Given this list of marker genes PPARGC1B, MAP3K6, DPF1, OPRL1, ASB7, CACNB1, MYBPH, ZDHHC14, OGDH, ELAVL4, TTN, MBD3, ACR, KIF1C, CCN3, PCBP4, ISL1, TOMM40L, FGF17, TUBGCP6, PRSS36, GABBR2, NRIP3, PTPRF, GCH1, FBXO3, CYBC1, FNDC5, GSPT1, CREB3 (NCBI Gene Id 10488), MYO18A (NCBI Gene Id 9799), ZBED5, SEMA6C, TP53BP1, IRS1, AP4S1, CHRD, IGDCC4, RLIM, FAM131C, AHNAK, DDX17, KLF13, INTS9, AGBL5, HS3ST2, EPO, ATP1B2, TIGD4, TP53, ARHGEF2, DDAH2, NR2F1, CBFB, DCTN1, AGER, PIP5K1B, AXL, AAK1, RRAD (RRAD, Ras related glycolysis inhibitor and calcium channel regulator), NECTIN1, BRD2, LRP5, MYL2, SLC12A5, MAP1LC3A, CACNA1A, REEP4, WNT5A, USF2, BMF, PFDN1, MAP3K11, TAOK1, GRIK1, SLC39A6, TAFA1 (NCBI Gene Id 494552), PA2G4, HAUS3, MAST2, JOSD2, FOXA2, WASF2, HOXC6, HS3ST4, HBEGF, NTN1 (netrin 1), DTX1, CPNE5, RPL10A, H2AC21, NAT8L, PTK2B, RAPGEFL1, GNAO1, TRAPPC3, IL2, ZFYVE1, MLLT10, SREBF2, UNG, ARRDC3, TMEM139, ITPKB, ZNF516-DT, FOXI1, SMARCB1, NUFIP2, LRFN4, GPR20, BMP7, DCX, BMP4, PPP2R3C, SEMA6A, ZBTB9, SP2, TLX2, PNKD (NCBI Gene Id 87830), ELOVL6, SLC16A2, RIPOR1, CERCAM, HOXB4, PMP22, TRIM46, MSC, S100A10, KLK7, CLC, LINC00656 (long intergenic non-protein coding RNA 656), CAV3 (caveolin 3), PLEKHA4, SFSWAP, PLEKHN1, ADAMTS12, CYLD, IL2RG, PRR7, RARRES2, LNPEP, CALML5, UBE2D3, RPRD2, RBL1, AQP4-AS1, ITGA5, PAX6, HSD11B1 (NCBI Gene Id 3290), ZEB1, ZSWIM3, LDB1, HOXB8, ZHX2, OSR1, KLF5, ZNF436-AS1, SLITRK2, STAG3, COL11A2, DNAJC7 (DnaJ heat shock protein family (Hsp40) member C7), RHEBL1, NR5A1, CIAO1, CDKN1B, TNIP1, C11orf87, CD38, TRIM55, GPC2, KMT2E, JUP, CDK6, CTNND2, TCEA2, MAP4, CAST, ZBTB7A, DDIT4, YBX3, PDK3, ABI3BP, GSE1, PTCHD1, VIM, PRDM1, RASSF2, FCGBP, SIX2, SBF2, ZFAND5, PPM1B, TLNRD1 (talin rod domain containing 1), H2AX, ATOSB, QPCT, TXLNG, DNAJC14, HDAC8, DBNDD2, POU2F1, KCNK10, SP7, SPARC, ASPHD1, ABHD1, EVX1, DTNA, TOM1L1, PPP2R2B, ESAM, IGSF3, DSG3, VPS16, SERPINB7, LUC7L2, HAS1, ADA, GNB2, IGFLR1, CRLF1, LAT, SHC1, HOXB2, GNAI2, NREP, CDKN1A, NMT1, ARHGEF15, TSPAN4, ERLIN1, MEF2D, TMSB4XP8, RAB1A, PTPN6, RFX1, PROCR, BCAR3, ZNF827, HNF1A, PTCH1, CLASP1, PRDX2, ITGA6, UBE2B (NCBI Gene Id 7320), SOX15, IGF2, AP1G1, OGA, NEUROD2, AQP4 (NCBI Gene Id 50660), ADORA2A, FRMD4A, NECTIN4, SEMA3G, LENEP, SPTAN1, PTMS, GPR119, PRRX1, GPM6B, ATP1A3, SH3GLB2, POLR2L, ATN1, KCNA1, RAC1, SPTBN4, STARD13, RAD23A (NCBI Gene Id 5886), DLX1, MSLN, PHF12, NTN4, PITX2, SPTY2D1, LYPD1, LINC00472, VCAN, NIN, PTPN12, NCAM2, TPM3, TLN1, MYL3, DOCK11, ATP6V1A (NCBI Gene Id 523), CD27, PKP3, AKTIP, WNT3, TSPAN17, PBXIP1, TPPP3, IGSF1, CDC42SE1, SRSF1, SIAE, CADM2, MAN2B1, TRIM39, SLCO2B1, TEAD3, SYNPO2L, EMILIN1, EFNB3, SERTAD4, PHLDB3 (pleckstrin homology like domain family B member 3), ADGRD1, RTKN, RBM3, WNK4, STAG1, SIK2, RASAL2, IMPDH2, JADE3, CLVS1, ARHGAP32, SLC38A5, ABI3, HDGF, RADIL, EIF4E, DLL4 (NCBI Gene Id 54567), NAA50, COL5A3, ENTPD1, FGFR1 (fibroblast growth factor receptor 1), TNKS1BP1, SLC4A1, CA11, LINC00303, MRTFA, FAM13B, ARL4C, CPNE9, JADE2, PPP2R5B, GABARAP, CITED1, SEPTIN7, CSK, NCALD, TAOK2, KRTCAP2, SHH, GUCA2B, GRIN2B, AZIN1, CACNA1E, MKNK2, MAP4K3, CD63, FBXO5, FAM120AOS, FBRS, DUSP8, KLHL40, EIF1AX, DMPK, DENND5A, SAMD1, MRPL49, SPHK1, ITGA2, RTN4, PAFAH1B1, HOXB6 (NCBI Gene Id 3216), FZD7, EEF1A1, WBP1, HOXC11, HNF1B, HCFC1R1, CCDC81 (NCBI Gene Id 60494), HNRNPF, HOXB13, TFAP2B, MID2, TSPAN1, CIP2A, KREMEN1, THBS3, DUSP5, TUBA4A, PKIA, LDHD, EN1, TMEM270, RNF11, ZNF296, CD109, LUC7L, PCGF5, EMSY, CCDC71, TAL1, CLIP3, KRTAP11-1, INHBE, NLGN3, BRWD3, PPM1D, RAD23B, PBX1, MPC2, ADD3, PYY2, NR1D1, PTPRN, KIF3C, FOXN3, PSD, NYAP1, RCOR2, FHL1, LGI2, PLCD4, CADM1, UBE2W, EHMT2, PFKFB1 (6-phosphofructo-2-kinase/fructose-2,6-biphosphatase 1), PRM2 (protamine 2), RPS6KA4, KCNMB1, SIX4, TAX1BP3, SHROOM1, GSX1, RASL11B, CSNK2A1, GIGYF1, DDA1, KLHL28, PTGR3, SKIL, DLG3, BAZ2A, FOLR1, PRKCE, TNPO3, LRRN2, EIF1AY, TSPAN13, UBE2F, NLGN2, BTK, DEPDC4, OAZ2, SLC9A6, SOX14, SPRY4, LRP1, RASIP1, KRT13, THPO, MN1, RTN4RL2, KPNB1, ARHGAP45, USP2, EDA, IRF9, PICALM, FXYD7, CYP26B1, SKIDA1, DEDD, WRAP53, GTF3C4, NR4A1, GRIA3, KAT5, PCSK1N, ARHGAP30, LRRTM4, HOXA10, ATP8B2, DPYSL5, EHF, TOGARAM1, SHKBP1, HSPA12B, ATG13, SLC25A37, TUBA4B, ADNP2, GADD45B, SRSF2, ANGPTL7, NHLH1, ETV5, MMP28, MPP2, C1QTNF7, AASDHPPT, PHKG2, SERPINE1, TRHDE, MOV10, NEDD4, ELK3, BARHL1, IGF2BP1, PPL, SEMA4C, DHCR24, HNRNPA2B1, NDRG2, C14orf119, TRIM41, C1QL1, ANXA4, ZBTB11, PHACTR3, SEMA7A, MAB21L3, BRD4, PPFIA2, KNTC1, MSN, WDR13, LINC02873, FGF11, USP12 (ubiquitin specific peptidase 12), CLCN6, DDX31, SPEN, SBSN, GNB4, SERPINB5, EBP, CCNA2, PRKAR2B, NHLRC2, TOR1AIP2, RAB25, HNRNPC, JMJD1C, MAG, CD55, SERPINI1, XPO7, FZD4, SMAD6, KLF3-AS1 (NCBI Gene Id 79667, KLF3 antisense RNA 1), ROGDI, PHYHIP, EPC1, HNRNPL, PRELP, IQGAP2 (IQ motif containing GTPase activating protein 2), KLF12, GPR173, SFRP1, DMTN, KCNH2, TAFAZZIN, TREML2, RMI1, CKMT1B, UBE4B, RUNDC3A, EFNB2, NOTCH2NLA, KRTAP6-1, HAPLN1, SEPTIN3, UBALD1, UBA1 (NCBI Gene Id 8247), SH2D6, RALBP1, CRIM1, SESN1, MARK2, SLC37A4, WFDC5, GPX2, SH3BP1, ZNF436, CDC42EP3, CGB5, KCNJ14, ANAPC15, EFNB1, PRDM14, SPTB, PIM1, LIMK2, ASIC1, HNRNPH2, PITPNC1, ZNF462, TUBB4A, CLCA1, EP300, SCN3B, AP1M1, PURG, RPRD1A, HR, FGFR4, POLD4, PIM2, NAB2, KLHDC3, MAP2K7, TEAD2, SCARF1, EN2, CBLL1, NOTCH2, GRM3, SLC6A20, RAB30, AKT1, MCTS1, KRT17, PRDM10 (PR/SET domain 10), PYY, ID3, PPP2R5A, RASA1, WASL, CPT1A, KCNH7, S100A1, AIMP1, LIF, GNGT2, NXPH1, HES7, COL17A1, ZNF800, NKIRAS2, GATA1, RGS19, ZBTB37, NCOA3, ARMC8, GPR162, HMGA1, ADAM11, GJB6, DZIP3, NTN3, FAM170A (family with sequence similarity 170 member A), EIF4EBP1, HIC1, TMEM169, MIS12, GMIP, CCIN, ARHGAP44, NOL4, RAB3D, MAB21L2, RUNX3, ATF2, UNC45B, LAG3, LRP2, SLC39A14, ATP5F1B, HOMER1, ZIC5, DHRS11, MFSD2A, CELF4, MAGED2, SYT6, CLUH, HSD17B1, GSDMA, OTX2, OVOL2, GRHL3, FOLR2, RHOA, DMKN, TOB2, ARHGEF1, SLC12A6, MATN1, NTF4, DCUN1D3 (defective in cullin neddylation 1 domain containing 3), RAB11A, ABCD1 (ATP binding cassette subfamily D member 1), FAM110D (family with sequence similarity 110 member D), S100A14, HOXC5, RPS6KB2, RAB6B, AKIRIN2, LASP1, DYNC1H1, ACVR1, MXI1 (MAX interactor 1, dimerization protein), SSBP4, FMNL3, MAX, JAKMIP2, FHOD1, RGS14, ELOC, AHR, NBL1, GLA, NEGR1, CDK2AP1, MTX1, TBX5, MAPT, TRAF4, TGFBR1, MORF4L1, P2RX3, MIR22HG, ARHGDIB, ARFIP2, MNT, PLS3, RTN3, DLG2, SPRR1A, SALL1, GRB7, C1orf43, MACROH2A1, ST8SIA1, NRG1, MBNL1, LGI4, KLK12, BAD, EIF1, SNX12, DAB2IP, KCTD9 (potassium channel tetramerization domain containing 9), DNAJB3, KRT25, RARG, CA10, SRF, COL9A1, WDR81, C2CD2L, CCND2, ELP2, INO80D, MEOX2, TRPV2, KDM3A, TRERF1, EGR3, CD37, TNNI2, SEZ6L, VWA1, FILIP1, KRT14, SOSTDC1, FLT1, EML2, BAHD1, OTUD5, CRYBA2, KCTD12, STAT3, IRF1, NRG2, WRN, ACBD5, LIN28A, PTGER1, LMX1A, PJA1, CRTAC1, SPRY2, PXN, ZDHHC8, SMARCA2, H2AC20, PLA2G4F, A1CF, SLC43A2, CBX8, FIBIN, SEZ6, SLC39A4, WDR47, NFATC4, ITGB7, PRKAG1, CCDC93, MRPL2, CDK5R2, ZNF532, SH3BGRL, ZNF513, IL6, CORO1A, RALB, SSBP3, HSD3B7, CIART, FLI1, DNMT3B, SLC41A1, THOC6, NAA15, TNFRSF13C, INTS13, ZNF710, GARIN4, APOBR, AGR2, TTC9B, RBMS2, RSRC2, KLF10, CDK12, ACTR1A, LBX1, MAP1A, ALX4, SPAG9, KLF7, EPHA1, GATA6, GRM7, BCAP31, HDAC1, PLCB3, CFL1, CPNE6, SCN8A, C6orf136, NRK, ABCG4, CACNA1G, NUMBL, SLC12A4, H2BC21, LINS1, OTUB2, AMMECR1L, PHF23, TBX3, GPC4, PITPNM1, RAB11B, PCED1A, PHF1, POU3F4, PDCD10, NID2, TMEM88, TRPM6, CCNYL1, S1PR4, ARFIP1, IGFBP6, ROCK1, PIAS1, S100A16, DCAKD, ELN, ABI1, HNRNPK, B4GALT2, FOXJ2, ZNF821, STMN2, YBX2, TSPOAP1, DCLRE1A, STAT6 (NCBI Gene Id 6778), RAB6A, RAD51B, AGPAT4, DCHS2 (NCBI Gene Id 54798), DCN, KDM3B, JADE1, AFF4, KLK13, SAP130, CCR9, SSTR3, NR4A3, SLC6A11, KRT12, HDAC6, NEDD4L, DMRTB1, MIR503HG, GRIN2D, SLC2A4, SMARCA1, ZNF593, ACAN (NCBI Gene Id 404712), ARF3, HOXC4, AP3S1, STX12, UTP18, TUB, ROBO3, MTHFR, CBX3, STMN4, CD2BP2, HHEX, COL13A1, ADGRE5, ZNF385A, PRDM13, TRIM8, TNXB, LZTS2, EXD1, RNFT1, ZCWPW1 (zinc finger CW-type and PWWP domain containing 1), FCHSD1, MTUS1, CFAP69, SYVN1, LYZL6, HEBP2, ZMAT4, MEIS2, PHOSPHO1, ANKRD13B, GEMIN7, RRAGD, ADAMTS9, ZNF521, GDPD3 (glycerophosphodiester phosphodiesterase domain containing 3), TREX2 (NCBI Gene Id 11219), EIF4G1, TCTA, PRPH, HSP90B1 (heat shock protein 90 beta family member 1), WNT2, HEY1, DAAM1, TOP6BL, AMER1, DPYSL2, R3HDM1, THRA, GMPPB, BMPR2, MAGED1, HBP1 (NCBI Gene Id 26959), GAP43, AGO1, VSIG2, CDK17, IGFBP5, RLN1, SMAD2, TOB1, ERF, GGN, WNT9A, SCAMP5, COPS7B, HNRNPR, ASIC2, COL1A1, NDN (NCBI Gene Id 4692), HCN4, EIF4G2, INPP4A, ZBTB32 (NCBI Gene Id 27033), RPS6KA3, KCNN3 (NCBI Gene Id 95947), FBXO36, YWHAG, DYRK1A, CDCA2, WNT6, ELAVL2, CCL25, RBP5, RBMS3, KYAT1, SOX10, CRK (NCBI Gene Id 1398), CPLX2, MAPK3, STRA6, YTHDF2, APBA1, DSG1, FLVCR2, ADAMTSL5, ADD1, CDX1, TFR2, ATP6V0C, GRK6, FERMT2, LAMB2, KYNU, PTGES, ITGA10, SLC9A5, RLN2 (relaxin 2), MSI1, KEL, CLMP (NCBI Gene Id 79827), NKX2-1 (NK2 homeobox 1), HK2 (NCBI Gene Id 3099), SMTNL2, FES, KCNQ5 (NCBI Gene Id 56479), CALCOCO1, YTHDF3, SPEG, IL17B, ORAI3, AGAP4, CNOT4, PTK7, TCF4, MTSS1, LMX1B, ADAMTS5, MAP1B, MAFF, HOXA5, C1orf21, ZNF143, BRME1, CNTN2, KLF3, ESYT3, LY6G6C, FAM89B, LNPK, ZFP91, KATNB1, CAPN5, ABR, SYNCRIP, EEF1A2, PLPP3, BLVRB, ATG12, SH3BGRL2, CHMP5, EMC6, ARMCX4, RAPGEF3, ARF5, TNPO2, YPEL4, CFTR, KIF5B, JUN, ARHGAP26, TMEM8B, FAM110A, UBE2Z, RGS8, FMNL1 (formin like 1), TRIM27, TMEM151A, KLC4, PYGM, ADGRB2, ANK2, MEA1, RORA, ZNF512, EIF4ENIF1, SRSF6, MTF1, PIGV, SIKE1, TRIR, TNS1, HYAL2, PDIA5, PLAT, MCMBP, RHOBTB2, ITIH3, GRIK3, PDGFB, CHRDL1, ARHGAP5, ARHGAP6, RASGRP2, ATXN1, FBXL16 (NCBI Gene Id 64481), PLEC, SRCIN1, SRRM4, ACTC1, BACH2, CD79B, LRFN5, ACIN1, WBP1L (NCBI Gene Id 54909), CDR2L, CHRM1, TMEM127, TNNC1 (NCBI Gene Id 7134), YWHAQ, FYN, IQGAP1, HNF4A, CBFA2T3, SQSTM1, MNAT1, FCHSD2, CKS1B, KIAA0586, MARCKSL1, COL6A3, OTUD7B, INCA1, GPR17, CNTF, GPR85, PVALEF, TBCC, LCOR, ARHGAP8, FGFR1OP2, SLITRK3, CPNE8, LYRM1, GJB4, PLXNB3, NFE2L1, ZNF579, TRPC7, HMBOX1, SLC25A24, CNTN6, ZNF287, TMEM119, WAC, SPOP, BCL6B, SCARF2, FHL3, TLK1, BEGAIN, FOXO4, PSME1, GPRASP1, FUT8, PECR, WNT3A, STAG2 (STAG2 cohesin complex component), THRAP3, HAUS4, IRX6, ADNP, FARP1, KCNK12, POLG2, SH2D3C, EMID1, MGAT3, HS6ST3, GOLT1A, FOXP3, CTNND1, MAPRE3, AMOT, ARHGEF12, MEX3B, POGZ, AUTS2, NFIX, ARPC2, YWHAZ (NCBI Gene Id 83242), MEX3D, PTGDS, RAB5C, CHP1, HPCAL4, MFSD5, RNF125 (NCBI Gene Id 54941), LIME1, UBE3A, NR3C1, PPP1R9B, TIMM9, EGLN2, PCF11, HARBI1, SOCS1, HEPACAM2, DSG4, LCK, IGF1, FAM53C, TRPC5, EPHB1 (EPH receptor B1), TCEAL9, CAVIN1, MORF4L2, FLNC, ZNF503, LINC03040, TMEM187, STRN3, ACOT8, ANXA7, EEF1G, SLC9A1, ELAVL3, ZIC4, ZIC2, MED12, NFE2L3, TAB2, KRIT1, SP4, CTCF, HTR1D, PLP2, PNKP, MSX2, KLF8, PRKD2 (NCBI Gene Id 51519), MYO1C, AJUBA, TPI1P2, MTF2, CDK4, PCSK2, HHATL, EVPL, MS4A1, WWP1, TUFT1, CS, STK10, CALHM5, ANKS1B, TGFB3, APOA5, CLSTN3, NCDN, POU5F1 (POU class 5 homeobox 1), YWHAE, SEMA3B, HIF1A, ATF7, PODN, DCHS1, TRMT112, CALHM2, A2M, KMT2A, RGMA, DHX15 (NCBI Gene Id 1665), VCL, KDM6A, ENO2, MEPCE, EPHB6, MIR9-1HG, HPSE2, GDPD2, HYAL1, BLMH, AAMP, CACNG2, TIMM10B, ZBTB5, BAG1, ABI2, ST3GAL2, USP50, CACNA1D (NCBI Gene Id 776), UBQLNL, PRKCG, NOS3, KBTBD3 (NCBI Gene Id 143879), TBCK, HOXB9, RNF38, IRF2BPL, FAM120A (family with sequence similarity 120 member A), GABRG2, ATP8B1, EIF5A, HSCB, MLLT6, ZFPM2, DCTN4, ODF2, SPA17, RAB10, ATOH8, TRIB2, HSPG2, RABEPK, KCND3, TIE1, here is a description of the gene set: Genes having at least one occurrence of the highly conserved motif M56 GGGTGGRR in the regions spanning 4 kb centered on their transcription starting sites. This matches the PAX4 transcription factor binding site V$PAX4_03 (v7.4 TRANSFAC). Human Gene Set: GGGTGGRR_PAX4_03 Comprehensive identification of all functional elements encoded in the human genome is a fundamental need in biomedical research. Here, we present a comparative analysis of the human, mouse, rat and dog genomes to create a systematic catalogue of common regulatory motifs in promoters and 3' untranslated regions (3' UTRs). The promoter analysis yields 174 candidate motifs, including most previously known transcription-factor binding sites and 105 new motifs. The 3'-UTR analysis yields 106 motifs likely to be involved in post-transcriptional regulation. Nearly one-half are associated with microRNAs (miRNAs), leading to the discovery of many new miRNA genes and their likely target genes. Our results suggest that previous estimates of the number of human miRNA genes were low, and that miRNAs regulate at least 20% of human genes. The overall results provide a systematic view of gene regulation in the human, which will be refined as additional mammalian genomes become available. from publication Xie X, Lu J, Kulbokas EJ, Golub TR, Mootha V, Lindblad-Toh K, Lander ES, Kellis M (PMID 15735639) studied in species Homo sapiens